Given this list of marker genes CHMP4BP1, CHMP1A, CCSAP (centriole, cilia and spindle associated protein), HNRNPU, CHMP6, HSPA1A (NCBI Gene Id 3303), PLK1, VPS4B, CHMP3, CHMP5, CHMP4A, RIPOR2, TPR, STIL, SPAG5, CHMP4C, DRG1, HSPA1B, CHMP2A, CHMP4B, SENP6, CENPJ, CEP97, SASS6, RCC1, GPSM2 (NCBI Gene Id 29899), CHMP1B, MAPK15, CHMP7, DYNC1H1, RNF4, CHMP2B, PDCD6IP, NUMA1, EML3, here is a description of the gene set: studied in species Homo sapiens Any process that modulates the rate, frequency or extent of spindle assembly. Spindle assembly is the aggregation, arrangement and bonding together of a set of components to form the spindle, the array of microtubules and associated molecules that serves to move duplicated chromosomes apart. Human Gene Set: GOBP_REGULATION_OF_SPINDLE_ASSEMBLY